The following is a description of a gene set: Genes up-regulated during transition from L1 (non-tumor, infected with HCV) to G1 (well differentiated tumor, infected with HCV) in the development of hepatocellular carcinoma. Human Gene Set: IIZUKA_LIVER_CANCER_PROGRESSION_L1_G1_UP studied in species Homo sapiens Using high-density oligonucleotide array, we comprehensively analyzed expression levels of genes in 50 hepatocellular carcinoma (HCC) samples with positive hepatitis C virus (HCV) serology (well (G1), moderately (G2), and poorly (G3) differentiated tumors) and 11 non-tumorous livers (L1 and L0) with and without HCV infection. We searched for discriminatory genes of transition (L0 vs. L1, L1 vs. G1, G1 vs. G2, G2 vs. G3) with a supervised learning method, and then arranged the samples by self-organizing map (SOM) with the discriminatory gene sets. The SOM arranged the five clusters on a unique sigmoidal curve in the order L0, L1, G1, G2, and G3. The sample arrangement reproduced development-related features of HCC such as p53 abnormality. Strikingly, G2 tumors without venous invasion were located closer to the G1 cluster, and most G2 tumors with venous invasion were located closer to the G3 cluster (P=0.001 by Fisher's exact test). Our present profiling data will serve as a framework to understand the relation between the development and dedifferentiation of HCC. from publication Iizuka N, Oka M, Yamada-Okabe H, Mori N, Tamesa T, Okada T, Takemoto N, Sakamoto K, Hamada K, Ishitsuka H, Miyamoto T, Uchimura S, Hamamoto Y (PMID 15710396), and this is the list of marker genes: PRCP (prolylcarboxypeptidase), FOS, MT1E, IGFBP3, MAF, C1R, SLC31A1, AMFR, RAB14, IGFBP4, ORM1, MT3, MT1H, BNIP3L, MT1F, FERMT2, ID2, AGL (NCBI Gene Id 178), C6orf120, CPEB3